The following is a description of a gene set: Neighborhood of XRCC5 X-ray repair complementing defective repair in Chinese hamster cells 5 (double-strand-break rejoining; Ku autoantigen, 80kDa) in the GNF2 expression compendium Human Gene Set: GNF2_XRCC5 species: Homo sapiens Neighborhood of XRCC5, and this is the list of marker genes: RAN (RAN, member RAS oncogene family), PRPF4, HNRNPC, PSMA4, BANF1, ATP5PB, MMADHC, SF3B2, HNRNPK, MCTS1, NONO, GRSF1, PSMB7, NCL, DHX15, EIF2S1, KPNB1, SFPQ, SNRPE, PSMD11, XRCC5, ZNF207, SYNCRIP, RBMX, MAPRE1, SSBP1 (NCBI Gene Id 6742), HNRNPF, RARS1, PRPF40A, SNRPD2, U2SURP, SRP54, MRPL3, CAPRIN1, DDX39B, SSRP1, SUMO1 (small ubiquitin like modifier 1, NCBI Gene Id 7341), IFRD1, PA2G4, SNRPG, SRSF3, PSMD14, ABCE1, SNRPB2, PSMA5, SNRPD3, RTRAF, HNRNPA2B1, PSMA3, HNRNPU, POMP, CPSF6, GNAI3 (NCBI Gene Id 2773), SEM1, COPS2, ILF2, BUB3, NAE1 (NCBI Gene Id 8883), CCT3, RPA1, PTGES3, TCP1, PSMC2, MAGOH, TARS1, OSR1, EIF4A1, HNRNPA3P1, UQCRC2, RTCA, IFT25, SRSF1, TARDBP, PSMA1 (proteasome 20S subunit alpha 1), SRSF10